The following is a description of a gene set: studied in species Homo sapiens Human Gene Set: GOBP_POSITIVE_REGULATION_OF_STRIATED_MUSCLE_CONTRACTION Any process that activates or increases the frequency, rate or extent of striated muscle contraction., and this is the list of marker genes: ATP2A1, UCN, MIR1-1, GSTO1, ADRA1A, HSP90AA1, KCNQ1, RGS2, NPPA, CHGA, TRPV4, ACTN3, ATP1A1 (ATPase Na+/K+ transporting subunit alpha 1), ACE2